The following is a description of a gene set: Any process that activates or increases the frequency, rate or extent of synaptic vesicle recycling. studied in species Mus musculus Mouse Gene Set: GOBP_POSITIVE_REGULATION_OF_SYNAPTIC_VESICLE_RECYCLING, and this is the list of marker genes: Pclo, Ppp3cc, Lrrk2, Dnm1, Sh3gl1, Picalm, Ap2m1, Tor1a (torsin family 1, member A (torsin A)), Dnm3, Bcl2l1, Abca13, Synj1, Plaa, Dnm1l, Mff, Nlgn1, Snap91